The following is a description of a gene set: studied in species Mus musculus Genes up-regulated in macrophages by aerolysin-related cytotoxic enterotoxin (Act) from Aeromonas hydrophila. A cytotoxic enterotoxin (Act) of Aeromonas hydrophila possesses several biological activities, and it induces an inflammatory response in the host. In this study, we used microarrays to gain a global and molecular view of the cellular transcriptional responses to Act and to identify important genes up-regulated by this toxin. Total RNA was isolated at 0, 2, and 12 h from Act-treated macrophages and applied to Affymetrix MGU74 arrays, and the data were processed using a multi-analysis approach to identify genes that might be critical in the inflammatory process evoked by Act. Seventy-six genes were significantly and consistently up-regulated. Many of these genes were immune-related, and several were transcription factors, adhesion molecules, and cytokines. Additionally, we identified several apoptosis-associated genes that were significantly up-regulated in Act-treated macrophages. Act-induced apoptosis of macrophages was confirmed by annexin V staining and DNA laddering. Quantitative reverse transcriptase-polymerase chain reaction (RT-PCR) and enzyme-linked immunosorbent assay were used to verify increased expression of some inflammatory and apoptosis-associated genes identified by the microarray analysis. To further confirm Act-induced increases in gene expression, real-time RT-PCR was also used for selected genes. Taken together, the array data provided for the first time a global view of Act-mediated signal transduction and clearly demonstrated an inflammatory response and apoptosis mediated by this toxin in host cells at the molecular level. Mouse Gene Set: GALINDO_IMMUNE_RESPONSE_TO_ENTEROTOXIN from publication Galindo CL, Sha J, Ribardo DA, Fadl AA, Pillai L, Chopra AK (PMID 12824169), and this is the list of marker genes: Tnip1, Bcl6b, Pim1 (proviral integration site 1), Srpra, Il1rn, Phldb1, Il18rap, Gadd45b, Vegfa, Herpud1, Ubb, Csf3, Ikbke, Nfkb1, Rhob, Pcdh7, Rreb1, Bcl3, Ccl4, Phlda1, Ccl3, Cebpb, Slc11a1, Itga5, Tnf, Gadd45a, Sqstm1, Bcl2l11, Marcksl1, Traf1, Ccl9, Tnfaip2, Ubc (ubiquitin C), Cd83, Ptpre, Ccl5, Cd14, Tnfsf9, Nab2, Actg1, Nfkbia, Tsc22d1, Lilrb4a, Spp1, Ets2, Cd44, Noct, Lilrb4b, Il1b, Slfn2, Slfn4, Dusp1, Tnfaip3, Scd2, Pdlim7, Glrx, Ier3, Odc1, Csf2rb, Socs3, Cdc42ep4, Ptgs2, Txnip, Pdgfa, Dusp2, Pkm, Bcl10 (B cell leukemia/lymphoma 10), Adora2b, Ehd1, Junb, Errfi1, Bhlhe40, Cxcl2, Plaur, Mt2, Nfkb2, Fosl1, Tapbp, Acod1, Gapdh, Rac2